The following is a description of a gene set: studied in species Homo sapiens Human Gene Set: HP_PALATE_FISTULA A fistula which connects the oral cavity and the pharyngeal area via the aspects of the soft palate. Palate fistula, and this is the list of marker genes: PDGFRA, ARHGEF38, RIC1, DLG1, DLX4 (NCBI Gene Id 1751), IRF6, ARHGAP29, COBLL1, NECTIN1, CDH1, BMP4, TP63, MSX1